The following is a description of a gene set: studied in species Homo sapiens Human Gene Set: GOBP_REGULATION_OF_INSULIN_SECRETION Any process that modulates the frequency, rate or extent of the regulated release of insulin., and this is the list of marker genes: SSTR5, SERP1, CHGA, PRKACA, CARTPT, BAIAP3, NPFF, ORAI1, MYRIP, CD38, SLC25A22, PTPN11, NOS2, GCG, INHBB, RAC1, SIRT6, ANO1, ISL1, ABCC8, HIF1A, MTNR1B, SLC30A8, PFKM, CPT1A, C1QTNF12, TRPA1, JAGN1, LEP, SYTL4, NKX6-1, KCNJ11, GCK, SYT7, ADCY8, PPP3CB, DYNLL1, SLC8B1, CELA2A, GNAZ, NDUFAF2, NLGN2, EFNA5, HNF4A, DOC2B, GNAI1, PLCB1, G6PC2, VSNL1, OXCT1, FOXA2, MPC2, FKBP1B, IFNG, LRP5, MCU, SIDT2, GHRL, TUNAR, CDK16, FFAR1, TM7SF3, IL6, GNA11, RPH3AL, MLXIPL, CRH, KCNB1, RFX6, HADH, ITPR1, SLC2A2, HLA-DRB1, AACS, PRKCA, GHSR, TARDBP, KLF7, PER2, UCN3 (urocortin 3), ALOX5 (NCBI Gene Id 240), PCK2, GLUD1, TCF7L2, CFTR, PRKAR1A, PPARD, OSBP, ENSA, FFAR2, TFAP2B, CAPN10, NNAT, BAD, CHRM3, GPR68, SYBU, TNF, C2CD2L, RBP4 (NCBI Gene Id 5950), RFX3, PHPT1, EPHA5, GIP, PFKL, PRKCE, CASR, CLOCK, PSMD9, UQCC2, PRKCB, GPR27, IRS1, JAK2, F2RL1, SIRT3, EIPR1, CCL5 (NCBI Gene Id 8147), PIM3, NEUROD1, ABCA12, GPER1, NR1H4, CCN3, TRH, GPRC6A, STXBP4, F2RL2, TCIRG1, BMAL1, SNAP25, STX4 (NCBI Gene Id 6810), ADRA2A, ACSL4, PDX1, ENY2, IRS2, FAM3D, PRKN, NR0B2, GNAO1, SREBF1, FOXO1, ZBED6, DRD2, GPLD1, UCP2, SLC9B2, SOX4, LRRC8A, SIRT4, IL1B, SRI, PICK1, MIDN, GNAS, STX1A, ABAT, PFKFB2, GIPR, PLA2G6, F2, NR1D1, TRPM5, KCNA5, PDE8B, ADRA2C, RAPGEF3, NADK, REST, SLC16A1, ADCY5, RAPGEF4, BRSK2, BLK, BMP8A, ACVR1C, KCNK16, TRPM4